Given this list of marker genes NEDD9, HECW1, ZCCHC14, HERPUD1, ZG16, ZBTB39, RORA, SLC1A3, MYCBP2, TMEM184C, LRRK2, EIF2S1, CCSAP, SERPINB7, KCNH8, SUPT3H, SLFN14, BCAP29, SLC22A9 (NCBI Gene Id 221106), NAT1, WNT8B, BRWD3, GALM, ZNF670, UGT3A1, CFAP45, PITPNA, HOMEZ, GREB1, here is a description of the gene set: from publication Chen Y, Wang X (PMID 31504780) Genes predicted to be targets of miRBase v22 microRNA hsa-miR-8078 in miRDB v6.0 with MirTarget v4 prediction scores > 80 (high confidence targets). species: Homo sapiens Human Gene Set: MIR8078